The following is a description of a gene set: species: Mus musculus Mouse Gene Set: chr10B2, and this is the list of marker genes: Gm47889, Smpd2, Gm19137, Tdg-ps2, Mir3473b, 1700027J07Rik, Gm29246, Mical1, Lin28b, Gm47815, 4933404K13Rik, 5730435O14Rik, 9930024M15Rik, Gm6983, Gm15200, Armc2, Gm35552, Gm23481, Sesn1, Snx3, Gm40634, Gm9068, F930017D23Rik, Zbtb24, Gm34006, Popdc3, Gm5950, Gm4795, Qrsl1, Gm22087, Ccdc162, D030045P18Rik, Mtres1, Sec63, Pdss2, Mir1929, Gm25650, Gm22503, Hace1, Gm15197, Gm35430, Scml4, Gm3699, Nr2e1, Rpl26-ps1, Gm40639 (predicted gene, 40639), Prdm1, Cd164, Gm17196, Ostm1, Speer5-ps1, Ppil6, Pam16l, 1700016J18Rik, Afg1l, Gm3442, Bves, Crybg1, Atg5, Gm18669, Gm5949, Cep57l1, Sobp, Rtn4ip1, Gm9034, Gm35154, Gm15199, Cd24a, Rps19-ps11, 4930431F10Rik, Gm26016, Bend3, Gm15934 (NCBI Gene Id 102638854), Gm35028 (predicted gene, 35028), Prep, Gm19994, Foxo3, Gm40638, BC048559, Gpx4-ps2